The following is a description of a gene set: Human Gene Set: HE_LIM_SUN_FETAL_LUNG_C7_PROLIFERATING_SCHWANN_CELL from publication He P, Lim K, Sun D, Pett JP, Jeng Q, Polanski K, Dong Z, Bolt L, Richardson L, Mamanova L, Dabrowska M, Wilbrey-Clark A, Madissoon E, Tuong ZK, Dann E, Suo C, Goh I, Yoshida M, Nikolić MZ, Janes SM, He X, Barker RA, Teichmann SA, Marioni JC, Meyer KB, Rawlins EL (PMID 36493756) studied in species Homo sapiens Proliferating Schwann, and this is the list of marker genes: EIF1AY, NUP85, CCDC77 (NCBI Gene Id 84318), ITGB4, LINC00342, HJURP, NAGA, TPP1, ZBTB9, PBK, UTRN (NCBI Gene Id 7402), SMIM10, CPT2, ITPR3, MKI67, CDCA3, MT1E, MASTL, ARSI (NCBI Gene Id 340075), COL4A5, SIX5, NMU, DAG1, SPATA6, ARPIN, TUBGCP3, CD82, TSPAN9, C1R, ZNF788P (NCBI Gene Id 388507), APOL2, ZMYM1, IER3IP1, ARHGEF39, CDCA5, PCDH7, CLN3, NPIPA1 (NCBI Gene Id 9284), LMCD1-AS1, LRRCC1, COBL, NR2F2-AS1, PRRT1, FGL2, PSMA2, HSPG2, DENND11, GNG11, LAMP5, LTBP4, ANKH, BBS1, DPY19L3, LRIF1, GLIPR2, BLM, EFL1, PREX1, PTPRD, DOLK, GPC3, STOX1, INTU, KIRREL3, PCBD2, LST1 (NCBI Gene Id 7940), MAP7D3, VEGFB, SLC39A3, GINS1, MAP6D1, LIAT1, NCAPH, PRC1, ARHGAP42, RELT (RELT TNF receptor), SFR1, SMIM5, METTL27, PLAAT3, MIGA2, PSMB8 (NCBI Gene Id 5696), EGFL8, ABTB2, MYO3A, POLD3, SPOUT1, BOLA1, CKAP2L, BSPRY, ISY1, LRRTM1, WDR76, N6AMT1, GFPT2, EED, ATL3, NAGLU, MATN2, BRME1, TLCD4, PASK, SLC1A4, RASIP1, CDT1 (chromatin licensing and DNA replication factor 1), AZGP1, NCAPD2, CAPN5, MIA, CENPU, MAPDA, MAL, FOXM1, CAVIN1, AATK, MT1F, ATAD2, TAF1B, TPPP3, VGLL3, SRGAP2B, LPAR1, ARHGEF10, GINS3, NTRK3 (NCBI Gene Id 4916), RCC1, RARRES1, SPP1, TMEM35B, RBBP8, NR2C2AP, HLA-B, NSF, TLL2, IFIT2, SCLT1, EFNB1, MGST2, JAG1, FAM72A, ABHD11, KIF4A, XKR4, PPIC, CDCA7, CRTAC1, TGFBR3, TCF19, SPMIP5, CDCA4, RETSAT, PRSS12, SERINC5, CDC20, NOTCH2NLA, ADAMTS16, PARPBP, DLGAP5, NXT2, TEX30, PIGG, MELTF-AS1, ZNF99, EME1, MPDU1-AS1, KIF20A, TSPAN18, SMAD3, SORBS2, CEP55, FAM111A, ANKRD28, EEIG1, DHRS4L2, RAD54B, MVK (NCBI Gene Id 4598), ARHGAP32 (NCBI Gene Id 9743, Rho GTPase activating protein 32), ACY1, CDCA8, NEK6, CCDC34, BACE2, C4orf33, MRPS17, MTHFSD, SWSAP1, LMF1, UGGT1, B3GAT1, TCIM, IQGAP3, E2F7, LIN54, C9orf40, SNAPC5, SLC25A40, FAHD2A, PDGFC, RAB38, CTSO, ART3, CDK1, KIAA1755, SSPN, ELK4 (NCBI Gene Id 2005), ENPP2, WIPF1, SLC10A7, CTSV, RGS9, TMEM38A, KIF2C, RAB35-AS1, AKAP11, CCNE1, ZFY, PLAUR, DSN1, TONSL, HPS5, GASK1B, SORBS1, ATP8B3, RELN, LRMDA, TMEM62, NTM (NCBI Gene Id 50863), ZNF596, MXD3, ITIH5, MAOB, PLEKHA4, OSGEPL1, MARCHF3, NAV2, CCDC15, AGA, CYP7B1, FRMD6, HEY2, ZGRF1, NUSAP1, SLC45A3, C11orf54, CLDN1, COL9A1, PPARA, NRAV, CDC14A, TULP3, POLD1, IFI6, BCL2L12, HBA1, ZNF233, KIF11, SPHK1, CTXND1, DEPDC1, EEFSEC, LRP10, ITGB8, BUB1, MAMDC2 (NCBI Gene Id 256691), RNFT2 (ring finger protein, transmembrane 2), LMCD1, ZBTB7A, BAIAP2-DT, VSTM4, VAMP5, RGMA, CCN3, RXRG, NEBL, COL28A1, ANGPTL4, MT1X, ECT2, CAHM, OGFOD2, ATP1A2, FGF7, TMEM45A, MAF, LHFPL2, TMEM214, MEGF10 (multiple EGF like domains 10), QSOX1, ERVK3-1, OSMR, NIBAN1, C21orf58, KIF18B, VPS18, CENPP, CERCAM, CDC25C, FKBP5, PI4KB, OLFML2B, VPS13D, RACGAP1, PON2, TTK, SP100, RNF26, PMP2, SUV39H2, OLFML2A, CASKIN2, STRADA, LOXL2, DNASE2, ZCCHC4, NEURL1B, SULF2, FBXO4, ZNF410, FBXO5, STIL, FAM72C, WWC1 (WW and C2 domain containing 1), TUBB6, RHOJ, GALNT7, MCM2, EEF1AKMT2, DCLRE1A, TRADD, ZNF367, FRMD4B, CRYBG3, GBP1, FHDC1, HIGD1A, SREBF1, HUNK, HBEGF, NEIL3, ZFHX3-AS1, SMCO4, SIPA1L2, ERAP1, NKILA, CENPJ, TAPBP, MYLK-AS1, IGFBP7, TMEM200B, AK5, EHD2 (NCBI Gene Id 30846), ALCAM, WWP1, BROX, NDUFA9, C1orf56, HTATIP2, COL19A1, ERI1, PRPS2, QNG1, ZNF578, BLVRB, CASP4, DHRS4-AS1, ARPC1A, SERPINA5, XRCC3, S100A4, TRIM52, APOBEC3B, CKLF (NCBI Gene Id 51192), SGO2, SFI1, APOA1, SOSTDC1, STRN, APBA3, CTNNA3, CLUAP1, COL4A1, PNPO, TACC3, F8A2, ZNF610, RASL12, NAV3, PPP1R3E, CCNB2, NRXN3, ELP4, URB1-AS1, DLGAP1-AS1, COL15A1, DDX11, FNTB, CLSTN2, IDE, MBD4, ERBB2, CXCL16 (NCBI Gene Id 58191), NBPF26, TMPO-AS1 (NCBI Gene Id 100128191), ADIRF, CNMD, NRF1, PHOSPHO2 (phosphatase, orphan 2), FLT3LG, RFLNA, CIDEB, KIF14, MDM1, KHNYN, GALK1, TNFRSF12A, GLRB, KITLG, LACTB2, PPP1R1C, SPA17, RAB20, RDH10 (retinol dehydrogenase 10), PRIMA1, PRKD3, NSUN7, OIP5, FZR1, ARL2, XKR5, FUT10, SLIT2, SGCE, FUT8, ZBTB14, POGLUT3 (NCBI Gene Id 143888), CCNT2-AS1, IFIT3, RTKN2 (NCBI Gene Id 254060), FAM98C (family with sequence similarity 98 member C), LINC02256, PRR11, USP40, NUF2, ALG6, SFTA3, SYT10, POC1B, MIF4GD, ALDH16A1, MTARC2, P4HA2, SLC35A2, CFAP91, FGF9, ADAM9, LIN9, PDK4 (NCBI Gene Id 5166), KANK2, RDM1, CENPN, WDFY1, LINC03072, RFC3, CHEK1, ZNF551, HSPB6, KCNMB4, ADCY6, KIF15, C16orf82, RNASE1, EFNA4, SBSPON, JDP2 (Jun dimerization protein 2), FKTN, TNS1, ARHGAP19, TBC1D4, PSRC1, SHMT1, UGT8, XYLB, LIMS2, MIR99AHG, GFRA3, TMEM176B, KIF18A, RPS4Y1, SKA1, HMMR, SOX3, BIVM, POC1A, PPP2R3B, RRM2, RBAK, RHBDF1, FST, CENPQ, CBR3, HTRA1, LPIN2, KANK4, EGLN2, PLCXD1, IFIT1, PEAK1, ALAD, FIRRM, BIRC5, GALNS, THBS3, TRAPPC13, JAK2, GTF2A1, ARHGAP18, SYS1, PPM1M, SNUPN, LPP-AS2, ANXA11, LRRC8C, PRXL2C, ARHGAP4, TFPI2, CYP27A1, CCNF (cyclin F), KBTBD3, EXO1 (NCBI Gene Id 9156), IRF3, RNFT1, ZNF239, HSPA2, SLC4A2, RPS21-DT, ZWILCH, GCNT1, THBS1, ELAC1, IFT80, SKIC2, SAMHD1, POLH, RIBC2, CENPH, PIGB, NPW, SH2D4A, MRPL53, ARAF, PACS1, ZNF317, DTL, ACBD4, TINAGL1, COL5A3, LPL, CEP112, CLMN, ADAM15, RASSF7, FEN1, KYAT3, MDP1 (magnesium dependent phosphatase 1), C14orf93, CA2, CENPE, TIMELESS, BDNF-AS, IRAK4, HEY1, ZNF90, TMEM107, JAM2, MND1 (meiotic nuclear divisions 1), PTPRE, LRR1, EPHA4, ASPM, FANCG, SDC4, PLK1, KIRREL2, RGS10, FN1, KNL1, MAL2, SV2B, LYRM7, SORCS2, PRRG4, C1orf54, UBE2C, C5orf34 (NCBI Gene Id 375444), SRCIN1, MBP, MAOA, ME3, TOM1L1, NCAPG, ZNF441, PCLAF, SPON2, NID2, DHODH, RRAS, ZDHHC5, PPT2-EGFL8, SPC25, TROAP, ANLN, DIAPH3, ZNF853, SRPX, CCDC102B, CASP7, ENG, C1QTNF5, ASXL2, GALNT11, BRCA1, NAPEPLD, CLSPN, PIGO, CYB5RL, PARD3B, MFSD5, ZNF865, CDC45, TBC1D31, NDE1, KIF1C, PPT2, DOCK5, FILIP1 (filamin A interacting protein 1), MSH5, DUSP14, DCLRE1B, HEPH, L1TD1, EMP3, P2RX6, TOR3A, IGFBP6, LGALS3BP, CAB39L, CHAMP1, RAD51AP1, FXYD3, C2orf76, NFKB2, GAS2L1, KCNE4, DTX2, ARSJ, TRIOBP, COMMD8, DHRS13, CEP192, MYO15B, PRELID2, TXNDC5, LIG1, ZNF343, FRZB, TRAIP, EPB41L4A-DT, TRIP13, ACER3, CLDN19, CENPO, IFI27L1, H2AC17, CDKN3, C2orf88, BGN, TMEM132B, ANXA3, SMIM30, ARHGAP15, ORC1, CCNB1, KIFC1, FDXR, PLEKHB1, PCYT1A, ZNF697, COL14A1, ROBO3, SAPCD2, IFI35, LGALS3, TRIM59, LRRC3, HSPA12A, MCM6, CENPL, TCTN1, ZNF488, HBA2, DSCC1, TMEM245, NFATC2IP, CENPK, H2AC16, PRSS23, ARHGEF6 (Rac/Cdc42 guanine nucleotide exchange factor 6), CCDC152, MNS1, WDHD1, HES4, PILRB, UTP14C, CENPA, JADE1, SLITRK5, UGDH-AS1, NFIA-AS2, PSMB9, RBM15, ANGPTL2, TOP2A, MYL9, TMEM19, VPS33A, GTSE1, ACADS, NDC80, LIMCH1, GINS2, TSPAN11, CRNDE, UBE2D4, GDPD5, ABLIM3, TMEM135, ORC6, REEP4, KDELR3, TBL2, NCAPG2, EVA1A, NQO2, SEPHS1, LAMA2, CAMK1, LRIG1, PIK3CA, ASF1B, BRCA2, CDC6, E2F2, POLR3F, DHH, CNN1, AFMID, KNSTRN, ZNF584, FANCB, TEX261, CCDC9B, PARP16, GABRA2, ZNF267, ZBTB44, CD83, DHRS3, GEN1, CD58, MIPEP, NFKB1, BMP1, IFI44, ZNF675, CLN8, NPB, COL11A2, SMIM11, FGF14-AS2, FOXRED2, MITF, SEC14L5, VWA1, CENPM, TRIM35, IL17RE, WWOX, SMYD4, MX1, BUB1B, RAD54L, NR2F1, SLC25A10, ESPL1, METTL4, GPER1, P3H2, ZNF595, CSTF2, KIF20B, NPLOC4, TXNDC11, DEPDC7, MAD2L1, CNBD2, GALNT18, RGCC, TNC, LYPD1, FAM111B, AP3M2, SPC24, IPP, ERLIN1, RAB31, GTF2H4, ZBTB40, AURKB, GAS2L3, CDC7, COL16A1, SOX8, ESPN, SNX24, PIGK (NCBI Gene Id 10026), ZC3H10, RAVER1, CDK18, LETR1, GBA1, NCAPH2, FBLN5 (NCBI Gene Id 11268), OPHN1, TRIM41, BMP8B, TRIM38, CLYBL, GMPPB, MAMSTR, RECQL (NCBI Gene Id 5965), RCN3, SH3KBP1, SLC25A21-AS1, INCENP, ADAMTS8, TMEM191C, TRIM68, PIEZO2, ANXA1, COPZ2, SH3D19, AVPI1, DCN, ERI2, NMT1, SHQ1, C8orf88, PIEZO1, CTNS, SOX13 (SRY-box transcription factor 13), RNASE4, KMT2E-AS1, GALM, SCAMP1-AS1, SYNM, PI4K2B, REXO5, ALOX15, PKMYT1, ST6GALNAC2, TAFAZZIN, TSPAN15, HBQ1, FAM83D, SFXN2, MPP1, TPX2, CCNE2, RNF180, CDKN2C, CHEK2, BORA, ZNF416, TYRO3 (TYRO3 protein tyrosine kinase), ZNF681, HAUS8, AGPAT2, TAF5, ATP2A1-AS1, MOV10, CNTN6, KAT2A, TNFAIP1, IQGAP2, FZD7, APOLD1, SPIN4, TAFA5, THAP9-AS1, BMP2K, ABCA8, ZDHHC6, FUZ, PHF19, PLTP, IGSF11, TEDC2, DUS1L, CDCA2, CLGN, ATF5, FAM156A, AUNIP, LRRC4, USP37, SEMA3G, MEGF8, DOK1, C6orf62 (chromosome 6 open reading frame 62), MYOZ1, PSMC3IP, CCNA2, PIMREG, ARHGAP26, WDR5B, ZBTB5, PROS1 (protein S), PRDM16, UHRF1, CSGALNACT1 (NCBI Gene Id 55790), COL22A1, POLQ, SSC5D, PRADC1, SGO1, ACAD9, HEXA, CTDSPL (CTD small phosphatase like), NEMP1, NFATC4, ZNF624, SH3BP5, NMI, AARSD1, CEP19, RFLNB, TUBGCP5, DEPTOR, DNAAF9, MYBL2, AQP1, PC, B4GALNT3, NR1H2, ALPL, DLG1, ESCO2, MBD2 (NCBI Gene Id 8932), TMC6, SLC9A8, SLC39A9, CHTF18, AASS, RAD51B (NCBI Gene Id 5890), WDR62, LMO7, NXPE3, WBP1L, NAB2, IQCJ-SCHIP1, FRMD3, LDLRAP1, FGF2, ZBTB12, TRIM47, NTRK2, VANGL1, PLP2, SLC30A6, BRI3BP, ITGB3 (NCBI Gene Id 3690), ABHD3, SCUBE2, SCN7A, RP2, HIRIP3, TMEM170A, PCTP, TK1, CEP85, CCDC18, SHCBP1, B4GALNT1, E2F8, REM1, SRGAP2C, NR2F1-AS1, NPAT (NCBI Gene Id 8067), ZNF718, USP6NL, MFGE8, TAP1, HAUS2, NNT-AS1, KDM5D, GLI4, FAM114A1, ROCK2, FAM76A, NEMP2, DHX34, L3HYPDH, SCML1, SYNPO, ALG9, ZWINT, SP110, C14orf28, COL5A1, GNG12 (NCBI Gene Id 55970), SLC1A5, SLF1, TIFA, TYK2, MELK, A1BG, PLK4, GAL3ST1, TMEM8B, NDST1, GPX8, ZFP1, URGCP, S1PR3, ICMT, ABCA1 (NCBI Gene Id 8371), TMEM38B, ARHGAP11A, PLXDC2, DHFR, CFI, PLSCR4, ZNF311, PCNX3, SKA3, MELTF, PACSIN3, CDH7, RNF135, AURKA, CPTP, CIB1, SCPEP1, KIF23, CHAF1B